The following is a description of a gene set: species: Homo sapiens Catalysis of the transfer of a stearoyl (systematic name, octadecanoyl) group to a sulfur atom on the cysteine of a protein molecule, in the reaction: octadecanoyl-CoA + L-cysteinyl- = CoA + S-octadecanoyl-L-cysteinyl-. Human Gene Set: GOMF_PROTEIN_CYSTEINE_S_STEAROYLTRANSFERASE_ACTIVITY, and this is the list of marker genes: ZDHHC15, ZDHHC3 (NCBI Gene Id 57245), ZDHHC6, ZDHHC20, ZDHHC7, ZDHHC2, ZDHHC17